Given this list of marker genes Cyp2c66, Cyp3a57, Cyp3a11, Cyp2c65, Cyp2d22, Cyp2f2, Arnt2, Cyp2j6, Cyp2a4, Cyp3a41a, Cyp3a41b, Cyp2a12, Cyp3a13, Cyp3a16, Cyp3a44, Cyp2e1, Cyp2c55, Cyp3a25, Cyp1a2 (NCBI Gene Id 13077), Cyp1a1, here is a description of the gene set: Reactome Pathway: Xenobiotics species: Mus musculus electronically inferred by orthology from the curated human pathway part of: Cytochrome P450 - arranged by substrate type This event has been computationally inferred from an event that has been demonstrated in another species.<p>The inference is based on the homology mapping from PANTHER. Briefly, reactions for which all involved PhysicalEntities (in input, output and catalyst) have a mapped orthologue/paralogue (for complexes at least 75% of components must have a mapping) are inferred to the other species.